Given this list of marker genes DKK1, MESP1, BMPR1A, PAX2, SIX2, HOXA11, WNT3A, SFRP2, TBX6, FGFR1, EYA1, EYA2, NODAL (nodal growth differentiation factor), here is a description of the gene set: The cell fate determination process in which a cell becomes capable of differentiating autonomously into a mesoderm cell in an environment that is neutral with respect to the developmental pathway; upon specification, the cell fate can be reversed. Human Gene Set: GOBP_MESODERMAL_CELL_FATE_SPECIFICATION species: Homo sapiens